Given this list of marker genes CMPK2, AK2, GUK1, AK5, CMPK1, DHODH, AK3, CAD (NCBI Gene Id 790), DTYMK, UMPS, AK1, ENTPD8, AK4, AK9, here is a description of the gene set: The chemical reactions and pathways resulting in the formation of a nucleoside diphosphate, a compound consisting of a nucleobase linked to a deoxyribose or ribose sugar esterified with diphosphate on the sugar. species: Homo sapiens Human Gene Set: GOBP_NUCLEOSIDE_DIPHOSPHATE_BIOSYNTHETIC_PROCESS